The following is a description of a gene set: The synthesis or release of any molecular mediator of the inflammatory response following an inflammatory stimulus, resulting in an increase in its intracellular or extracellular levels. studied in species Mus musculus Mouse Gene Set: GOBP_PRODUCTION_OF_MOLECULAR_MEDIATOR_INVOLVED_IN_INFLAMMATORY_RESPONSE, and this is the list of marker genes: Lipa, Snx4, Tarm1, Vamp8, Grn, Trem2, Lilrb4b, Alox5ap, Myd88 (NCBI Gene Id 17874), Chil3, Pld3, Lep, Tnf, Ephb2, Card9, Prdx2, Abcd2, Traf3ip2, Syk, Chid1, Il17ra, Ankrd42, Il22, Dusp10, Apod, Seh1l, F2, Adora3, Il17rc, Serpine1, Ins1 (NCBI Gene Id 16333), Pbxip1, Rps19, Stat3, Appl1, Nos2, Nppa, Slc18a2, Clec7a (NCBI Gene Id 56644), Ywhaz, Per1, Pycard, Pdcd4 (programmed cell death 4), Il17b, Mir324 (NCBI Gene Id 723896), Lbp, Rab44, Chrna7, Slc7a2, Chil6, Tlr4, Mapk14, Mapk9, Il17d (NCBI Gene Id 239114), Prkca, Ezh2, Extl3, Il4ra, Ephx2, Il1r2, Spink7, Hmox1, Snap23, Btk, Adam17, Pla2g3, Macir, Kpna6, Rap1gds1, Fcer1g, Cd300a, Chil5, Cuedc2, Itgb6, Sirpa, Chil4 (chitinase-like 4), Nod2 (nucleotide-binding oligomerization domain containing 2), Alox5, Ido1, Il22ra1, Hif1a, Cd96, Ticam1, Gbp5, Lilrb4a, Il6, Tlr3, Ins2, Gpsm3, Jak2, Il17f, Il17c, Lyn, Chia1, Reg3g, Ncf1, Fads2, Bap1, Ppara, Appl2 (NCBI Gene Id 216190), Il17a, Zc3h12a, Cd6, Slamf8, Tlr6 (toll-like receptor 6), Abcd1, Mefv, Pld4, Nlrc3, S100a9, Adcy7 (adenylate cyclase 7), P2rx1, Pla2g10